Given this list of marker genes NDEL1, PAFAH1B1, ZMIZ1, DISC1, DAB1, FOXG1, here is a description of the gene set: The radial migration of a pyramidal neuron along radial glial cells. Human Gene Set: GOBP_RADIAL_GLIA_GUIDED_PYRAMIDAL_NEURON_MIGRATION species: Homo sapiens